The following is a description of a gene set: studied in species Mus musculus Mouse Gene Set: GOBP_PYRIMIDINE_NUCLEOSIDE_MONOPHOSPHATE_BIOSYNTHETIC_PROCESS The chemical reactions and pathways resulting in the formation of pyrimidine nucleoside monophosphate, a compound consisting of a pyrimidine base linked to a ribose or deoxyribose sugar esterified with phosphate on the sugar., and this is the list of marker genes: Upp2, Dut, Uprt, Upp1, Shmt1, Cda, Umps, Uckl1, Nme3, Dhfr, Shmt2, Tyms, Cad, Uck2 (uridine-cytidine kinase 2), Uck1, Nme1, Dck, Dctd, Dhodh, Nme2